The following is a description of a gene set: Human Gene Set: GOBP_POSITIVE_REGULATION_OF_TUMOR_NECROSIS_FACTOR_MEDIATED_SIGNALING_PATHWAY Any process that activates or increases the frequency, rate or extent of tumor necrosis factor-mediated signaling pathway. studied in species Homo sapiens, and this is the list of marker genes: CASP4, CASP1, MMP8, CPNE1, CDK5R1, ADAM17, RIPK1, NRDC, ADAM10 (NCBI Gene Id 102), TRIM32 (tripartite motif containing 32), UBE2K, PRKN, HSPA1B, TRAF2, LAPTM5, MIR1246, HSPA1A